Given this list of marker genes SYT1, ha17, VAMP2, SYT2, HA-33, botB, ntnha, ha70, here is a description of the gene set: part of: Neurotoxicity of clostridium toxins species: Homo sapiens Reactome Pathway: Toxicity of botulinum toxin type B (botB) Botulinum toxin type B (botB, also known as BoNT/B), a disulfide-bonded heavy chain (HC) - light chain (LC) heterodimer, enters the gut typically as a result of consuming contaminated food, as a complex with nontoxic nonhemagglutinin protein (NTNHA, encoded by the C. botulinum ntnha gene) and multiple copies of three hemagglutinin proteins (HA, encoded by the C. botulinum ha17, ha34, and ha70 genes). The complex protects the toxin from degradation in the gut and mediates its association with the gut epithelium and transcytosis to enter the circulation. Circulating toxin molecules associate with gangliosides and synaptotagmin (SYT) proteins exposed by exocytosis at a synapse of a target neuron. Vesicle recycling brings the toxin into the neuron where the vesicle is acidified. The lowered pH induces a conformational change in the toxin: its HC forms a passage in the vesicle membrane through which its LC is extruded into the neuronal cytosol. Tthe HC - LC disulfide bond is reduced. The LC then catalyzes the cleavage of vesicle-associated membrane protein 2 (VAMP2) on the cytosolic face of synaptic vesicle membranes, thereby inhibiting synaptic vesicle fusion with the plasma membrane and exocytosis.